Given this list of marker genes USF3, KRT10, SDHC, PIK3CA, KRT1, KLLN, SDHD, SDHB, AKT1, PTEN, SEC23B, here is a description of the gene set: Conjunctival hamartoma Human Gene Set: HP_CONJUNCTIVAL_HAMARTOMA species: Homo sapiens A hamartoma (disordered proliferation of mature tissues) of the conjunctiva.